The following is a description of a gene set: species: Homo sapiens Human Gene Set: HP_ABNORMAL_LEUKOCYTE_ENZYME_CONCENTRATION_OR_ACTIVITY Abnormal leukocyte enzyme concentration or activity Concentration or activity of an enzyme as measured in leukocytes is above or below the limits of normal., and this is the list of marker genes: MAN2B1, ARSB, MPO, SGSH, ARSA